The following is a description of a gene set: Human Gene Set: HP_APLASIA_HYPOPLASIA_INVOLVING_BONES_OF_THE_THORAX species: Homo sapiens Aplasia/Hypoplasia involving bones of the thorax, and this is the list of marker genes: LMX1B, ALDH1A2, FBN1, RPS19, CASZ1, EVC2, SMO, ALG12, VPS35L, GNPTAB, PCGF2, FGFR3, IDUA, NUP88, HOXD13, RIPK4, LMNA, B4GALT7, FRA10AC1, MEG3, NIPBL, GPC3, EVC, PRIM1, B3GALT6, TAPT1, DYM, IFT81, NFIX, MMP23B, PTCH1, FIG4, BCOR, LBR, ALPL, TRIP11, EFNB1, DYNC2I2, B4GAT1, PORCN, LEMD2, SLC35D1, LAMA5, SETBP1, MSX2 (msh homeobox 2), FGFR1, CPLANE1, SKI, CSPP1, FLNB, PRDM16, POR, SRCAP, PTPN11, DYNC2I1, WNK3, TBX3, DPYSL5, KIAA0586, NAA10, NKX3-2, INTU, NEK1, WASHC5, TBX5, SOX9, TBX6, DHCR24 (24-dehydrocholesterol reductase), XYLT1, SF3B4, LUZP1 (NCBI Gene Id 7798), RBM10, PAICS, FLI1, ACTB, CEP152, IFT172, LRP2, DYNC2H1, KYNU, BUB1B, SPEN, IFT140, FLNA, KCNAB2, CHST3, SNRPB, DONSON, PUF60, WNT7A, DYNLT2B, SALL4, HSPG2, ATR, BGN, CHD6, NOG, ORC1, ORC4, PIGL, CBFB, PLCB3, PAM16, TRPV4, COL11A1, CDC42BPB, SLC26A2, RSPO2, COL2A1, ARID1B, WDR35 (NCBI Gene Id 57539), FUZ, ALX4 (NCBI Gene Id 64068), DDRGK1, HDAC6, EZH2, TBX15, GMNN, PTDSS1, UBA1, RERE, PCNT, PTEN, TRPV6, PSMB8, CCDC22, IFT80, PDPN, BMPER, UBE4B, HNRNPR, BMP2, CEP120, NFASC, ATP7A, FRAS1 (Fraser extracellular matrix complex subunit 1), INPPL1, FAT4, PRKCZ, DCHS1, ERMARD, SIX6, CDC45, RRAS2 (NCBI Gene Id 22800), TWIST1, IFT43, B3GAT3, CTSK, VANGL1, NALCN, FBXL3, TBC1D24, SCUBE3, TBCK, IHH, PTH1R, ORC6, TBX4, DLK1, WNT3, RNU12, RTL1, C2CD3, KMT2A, DNMT3A, GPC4, GPX4, NSDHL, COL11A2, GABRD, ZMPSTE24, BMPR1A, SOX2, IFT122 (NCBI Gene Id 55764), SCARF2, RNU4ATAC, MYF5, HES7, DYNC2LI1, RUNX2, VAC14, CDT1 (chromatin licensing and DNA replication factor 1), TOR1A, CHD4, FGFR2 (NCBI Gene Id 2263), ATP6V1B2, CENPJ, RNU4-2, GSC, ROR2, CUL7, DDR2, CDC6